Given this list of marker genes NKIRAS1, TAB2, CHUK, NKIRAS2, USP18, NFKB2, UBC, IRAK2, S100A12, MAP3K7 (NCBI Gene Id 6885), NOD2, TP53, RPS27A, IRAK1, AGER, UBE2V1, UBE2N, UBB, TRAF6, HMGB1, APP, NFKB1, S100B, TIFA, LRRC14, NFKBIA, NLRC5, IKBKG, RELA, IKBIP, NFKBIB, TAB3, TRAF2, UBA52, USP14, RIPK2, CASP8, ALPK1, IKBKB, SAA1, N4BP1, TAB1, NLRX1, NOD1, here is a description of the gene set: Human Gene Set: REACTOME_TAK1_DEPENDENT_IKK_AND_NF_KAPPA_B_ACTIVATION TAK1-dependent IKK and NF-kappa-B activation studied in species Homo sapiens